Given this list of marker genes PHAF1, TNRC6C, MRPS21, VASP, RPP14, PPP1R14B, ARL1, EPHX1, PRKCH, TCF12, PTGER1, UTF1, KRBA1, INTS6L, IRF3, ZFX, ICE1, CAPZB, INTS13, ERRFI1, EDN2, ZMYM5, PDIA6, C2orf49, PRPF8, VAV1, SF3A2, MSI2, MECR, C2orf42, NLGN1, DMAP1 (NCBI Gene Id 55929), TMEM184C, HGSNAT, WDR83OS, NSUN2, RRP36, TBC1D23 (TBC1 domain family member 23), CERT1, FBXO28, PRRC2A, CSNK1D, CCT8, CAD, RRN3, CYB5RL, ZFAND2A, ST13, SRP14, BBLN, LCP2, NDUFAF4, EVC, GRAMD1A, ZKSCAN3, EGR4, SPAG1, MFSD1, TNFSF14, KRT71 (keratin 71), PCDH20, CCSER2, WDR36, PRPF40B, LDAH, DNAJC5, PPP2R2A, C7orf25, RBKS, AGO2, CTDP1 (NCBI Gene Id 9150), RABL6, CCDC137, ATP6V1C1, RANBP3, DGCR2, SEPHS1 (selenophosphate synthetase 1), JAG1, IMP3, HSPA4L, PUF60, PUS7, CCDC107, TRAPPC2, MED31, SLC29A2, RASGRP1, PPIF, AP5M1, C12orf43, SFSWAP, MEG3 (maternally expressed 3), HAL, RAB40C, COPZ1, PADI1, UBE2I (ubiquitin conjugating enzyme E2 I), DESI2, CSDE1, LARP1, STX5 (NCBI Gene Id 6811), PHLDA1, FUBP1, POFUT2, LCP1, SIMC1, H2AJ, FNBP1, SRP68, HLA-C, ATG5, XPC, METTL1, SF3B3, TEFM, RNF123, FYCO1, MSN, TFG, FAM120B, SF1, TUBGCP5, CCT2, DPH6, CLCN1, NFYC, IL1R2, C3orf62, ANGPT2, IRAK4, E2F4, RALGPS2, DYNLT2, RHBDD2, ACVR1B, IDNK, TFIP11, CBLL1, GPCPD1, DLX1, B3GNT3, ATP6V1B2 (NCBI Gene Id 526), SPHK1, BPIFA2 (BPI fold containing family A member 2), KANSL1, SRM, PDE1B, ISYNA1, ITCH, ZYX, TRIM8, YTHDC1, KRTAP19-3, RGS2, GPHN, SLCO1A2, PSME3, ZFP2, CCT3, BLOC1S3, TPRG1L, SP5, TP53INP1, GPRC5C, NIPBL, SPPL3, ELMO3, PLPBP, NCOR1, ZMPSTE24, ARAP1, ECE1, ELP3, MRPL21, DNAJB6, MTARC2, RNF6, VPS16, JAK1, MGA, TLK2, DNMBP, UGT2A3, USP47, RPS6, NUFIP1, RSPH9, PDCD7, SKIL, UBC, UBL3, CHRNB2, GPATCH4, ANKS1A, IKBKE, CPA1, SH2B3 (NCBI Gene Id 10019), ETNK1, C6orf62, MEA1, here is a description of the gene set: studied in species Homo sapiens from publication Ng SY, Yoshida T, Zhang J, Georgopoulos K (PMID 19345118) Regulation of lineage potential and transcriptional priming by Ikaros. New insight is provided into a bivalent regulation of lineage priming in the HSC and its lympho-myeloid restricted progeny the LMPP by the lymphoid lineage-determining factor Ikaros Whereas Ikaros is responsible for the activation of a cascade of lymphoid expression programs and for the establishment of lymphoid potential from the HSC to the LMPP it is also responsible for the repression of stem cell and erythroid genetic programs that are incompatible with further lineage restrictions emanating from the LMPP Genes up-regulated in hematopoietic stem cells versus granulo-monocyte progenitors. Human Gene Set: GSE15330_HSC_VS_GRANULOCYTE_MONOCYTE_PROGENITOR_UP